Given this list of marker genes PPP1R7, TOP2B, SLC7A1, UBN1, CAPN3, RPGR, GYPC, RET, SPAG11B, CARS1, JMJD1C, CBX1, ZHX2, TGM5, MRPL33, ALOX5AP, MMP17, AK4, PIM1, CLN5, PTP4A3, ADAM23, PCYT1B, ERG (NCBI Gene Id 2078), CCN2, SLC36A1, IGF2BP3, PLAGL1, GLT8D1, SMC1A, STAM, ARHGAP45, IFI35, RBPMS, MYH9, COL6A2, LYSET, SDHB, NPRL3, KXD1, PRDM2, NR3C1, CLDND1, PYGM, VPS13D, CHRNA2, EMP2, PCDHA3, ELP1 (NCBI Gene Id 8518), OSTF1, GFRA1, ENPP4, EIF4E2, PIK3CD, BCL2 (BCL2 apoptosis regulator), NARS1, IL10RB, NCOA6, BMI1, HPS5, MAPKAPK3, C2CD5, ADIRF, DPP4, GPM6B, ATP6V1E1, NDUFA1, CD79A, PLAUR, NDUFB3, PTH2R, SEMA3C, ITM2A, ADCY3, AK2, WFS1, CCND2, ZNF280A, IMPG1, HSPG2, NDUFS3, ERP29, CAPG, TWF2 (twinfilin actin binding protein 2), COQ2, SPAG6 (sperm associated antigen 6), PUDP (NCBI Gene Id 8226), CD81, SLC5A1, CD2AP, SAMD4A, CLTA, DACH1, FZD6, TMC6, CTIF, IVD, TACC1, TPD52L2, RPS6KA3, ANXA5, KBTBD11, PSMD7, SLC1A4, TENM1, FAM169A, IL2RG, FEZ1, KHK, NEK4, ITGAE, CPD (NCBI Gene Id 1362), CYP4F12, TEKT2, LAMTOR5, DDX39A (DExD-box helicase 39A), IL9R, TBXA2R, RGS19, PPP1R2, PLS1, GGT1, ADCY7, DMXL2, IDH3A, RNASE2, CYP4A11, PRPF18, CCND3, CAMTA2, GH2, HMGA2, CSTA, LCP1, NPR3, TTLL12, QKI, CPM, ST3GAL6, MYO6 (NCBI Gene Id 4646), GPR68, SNX17, MAGED2, YWHAH-AS1, SFI1, CDR2L, SF1, SASH1, GLUL, TBX1, PPID, ABHD3, KRT10, SYF2, DEXI, GMPR, AP1S2, ATP1B1, LALBA, TRIM44, PPP2R5C, LDB1 (LIM domain binding 1), ALB, CD68, DPY19L1, GRIK2, ATM, STS (NCBI Gene Id 6802), SMPDL3B, S100A10, MAPK9, SLC16A5, NTRK1, IDS, OVOL2, LRIG1, MRTFA, ITGAV, IL6R (interleukin 6 receptor), KLHL35, ARHGEF18, SLC27A2, ADAM15, UBE2N, RASGRP2, YES1, CSPG4, GCLC, ANGEL1, CYBB, EVI5, TNPO1, EXOG, TCL1A, BAP1, SLC25A13, HFE, ADAM10, LAPTM5, PSKH1, ALDH3A2, CALCOCO2, ACTA1, INSR, FOLR1 (NCBI Gene Id 2348), FOXJ1, GLRB, PRDX1, FCGR1A, CILK1, SLC25A42, BMP7, JTB, SMAD1, PRKCQ, IMPA1, TAF1B, TNNI1, JAK3, FTO, AEBP1, NDUFS6, MED13L, PPT2, UTP18, FOXC1, MBNL1, COX5B, DIP2C, THOC5, SOCS2, GPS2, ELK3, SAG, GTF2E2, POP5, PRKCB, DDT, MEF2C, BLNK, ABCC6, DGKD, SHC3, CAMK1, OFD1, CHKB, PREP, VIPR2, DDAH2, TFAP2B (NCBI Gene Id 7021), DNAJC16, RASGRP3, CEBPG, NR2C1, DHX16, GMDS, ATXN1, ENTPD1 (ectonucleoside triphosphate diphosphohydrolase 1), CAST, PRKAG1, TEX30, ELP4, CDK9, GDI2, CRADD, ELAVL3, ATP5PD, TMEM131L, LDAF1, PPP1CA, GNAI1, PVR, MCF2L2, TAL1, DOP1B, MLF2, ABR, IFNA5, IRAG2, TIMP3, NUDT3, GPM6A, SELENOW, ANPEP, GAS7, PLCG2, CTDSPL, TFDP2, PBX3, EIF4EBP2, NFATC3, EIF2S2, MEIS1, XKRY, CD79B, HCLS1, ITPR2, EIF2B4, SUPT5H, NFIX (NCBI Gene Id 4784), LGALS1, NAA80, ATPAF2, ADAM18, DHCR7, N4BP2L1, MICB, POLR2G, LRP10, NELFE, ITGA7, MPL, ADCY9, RARRES2, SRSF8, GDF7, HDAC9, BLOC1S1, MPPE1, FSCN1, NKX2-8, RANBP6, AKR1B1, RB1, ZNF91, RGS10 (regulator of G protein signaling 10), FBXO46, DEPDC5, LUM, CADM1, ADA, XBP1, RANBP2, ADH5, PHF2, SEL1L3, HIP1, WARS1, EMID1, SLF2, TSPAN4, LIN7A, CS, here is a description of the gene set: species: Homo sapiens Genes specifically expressed in samples from patients with pediatric acute myeloid leukemia (AML) bearing 11q23 rearrangements. from publication Yagi T, Morimoto A, Eguchi M, Hibi S, Sako M, Ishii E, Mizutani S, Imashuku S, Ohki M, Ichikawa H (PMID 12738660) Most patients with acute myeloid leukemia (AML) enter complete remission (CR) after treatment with chemotherapy, but a large number of them experience relapse with resistant disease. To identify genes that are associated with their prognoses, we analyzed gene expression in 54 pediatric patients with AML using an oligonucleotide microarray that contained 12 566 probe sets. A supervised approach using the Student t test selected a prognostic set of genes, some of which are associated with the regulation of cell cycle and apoptosis. Most of these genes had not previously been reported to be associated with prognosis and were not correlated with morphologically classified French-American-British (FAB) subtypes or with karyotypes. These results indicate the existence of prognosis-associated genes that are independent of cell lineage and cytogenetic abnormalities, and they can provide therapeutic direction for individual risk-adapted therapy for pediatric AML patients. Human Gene Set: YAGI_AML_WITH_11Q23_REARRANGED